The following is a description of a gene set: studied in species Homo sapiens Human Gene Set: GOBP_NUCLEIC_ACID_CATABOLIC_PROCESS The cellular DNA metabolic process resulting in the breakdown of a nucleic acid., and this is the list of marker genes: INTS1, NORAD, FXR2, HSPA1A, PKP3, EXOSC4, MIR142, GTPBP1, ZC3H18 (NCBI Gene Id 124245), MIR181A2, UPF3A, TENT4B, RNPS1, EXOG, CECR2, CNOT9, MIR497, PCBP4, SLIRP, XIST, XRN1, POP1, MIR663A, FASTK, MIR20B, RNASE2 (NCBI Gene Id 6036), MIR608, PNRC1, MIR34B, DNASE1L3, PHAX, RIDA, SETMAR, MIR302A, DNA2, MIR149, PATL1, TRDMT1, DIS3L, MIR708, GATA5, MIR100, FASTKD5, NBAS, NUDT12, SMG6, TBRG4, TENT5D, DIS3, FASTKD1, MIR181D, PNRC2, METTL16, EXOSC9, PLEKHN1 (NCBI Gene Id 84069), LARP1, INTS11, DHX34, RNASEL, AGO4, HOTTIP, BAX, ERI1, CNOT3, ZFP36L1, MIR140, SKIC2, MIR18A, METTL1, PPP1R8, HNRNPD, C1QBP, RBM24, FEN1, PABPC1, XRN2, EIF4A3, NUDT16, ZC3H12A, NOCT (nocturnin), DCP1A, MIR340, INTS3, CAPRIN1, ATM, DFFA, DAZ2, CNOT8, FMR1, ZC3H4, EIF3E, TNRC6B, CNOT10, QKI, MIR214, MIR93, FXR1, AGO3, TARDBP, ELOC, VIM (NCBI Gene Id 7431), MIR130A, OAS2, NBDY, SND1, MIRLET7B, GRSF1, CIDEA, NANOS3, LSM4, TENT5B, GSPT2, CNOT11, NMNAT1, NPM1, DFFB, MIR23A, FASTKD2, MIR181C, MIR27B, INTS10, MIR486-1, DNASE1L2, MIR1-1, APOBEC1, TRAF2, TENT4A, PUM2 (pumilio RNA binding family member 2), ELOB, RBM38, MIR200B, FOXL2, MIR365A, MIR146A, RNASE6, MIR203A, MTPAP, SMG5, A1CF, RBM33, PRR5L, NANOS1, MUS81, TAF15, DEDD2, ELAC2, MIR130B, CIRBP, RNH1, NRDE2 (NRDE-2, necessary for RNA interference, domain containing), INTS15, MOV10, ZPR1, NSUN4, GIGYF2, AKT1, FTO, TNFRSF1B, CELF1, CNOT2, EXOSC1, E2F1, SMG8, SKIC8, HNRNPA0, DCP1B, DNASE1, CALCR, INTS6, ANGEL2, PKP1, WDR82, PABPN1L, YTHDF3, MAGOH, TUT4, CNOT6, RBM8A, PABPC4, ROCK1, EXOSC5, MAPK14, YBX3, IGF2BP3, DIS3L2, MIR625, MIR204, MIR326, TTC5, ROCK2, ZC3H12D, RNASEH2A, THRAP3 (NCBI Gene Id 9967), PELO, CSDE1, SLFN14, FUS, PAN2, HNRNPC, ZC3H14, IREB2, INTS4, TENT2, RNASE3, PNLDC1, DAZ4, UPF1, TESK1, DXO, SLC11A1, MIR200C, MIR199B, ZFP36, CNOT7, KHSRP, MIR329-1, DNASE1L1 (deoxyribonuclease 1 like 1), MIR106A, LSM2, PIWIL1, MIR137, DNASE2B, TREX1, MRTO4, UPF3B, ZCCHC8, MIR128-1, VIP, RC3H2, INTS14, ALKBH5, ELAVL4, NEAT1, PIWIL2 (piwi like RNA-mediated gene silencing 2), MIR302C, SUPV3L1, TNRC6A, CNOT6L, CARHSP1, LARP4B, ARID5A, LSM14B, DAZ3, DDX49, SKIC3, MEIOC, MIR27A, METTL14, NICOL1, TUT7, RBX1, LIN28A, SLFN12, MIR135B (microRNA 135b), DND1, ZHX2, LRPPRC, SERBP1, MIR195, SCGB1A1, IGF2BP2, DHX36, SSB, INTS12, HNRNPAB, DAZL, SAMD4A, POLR2G, OIP5-AS1, MIR30B, DDX5, MIR211, SENP1, ZAR1, ZFP36L2, APAF1, INTS13, PNPT1, MIR125B1, ANG, TUT1, HNRNPU, TOB1, MAPKAPK2, DCPS, DHX9, EIF4ENIF1, ISG20, RNASEH2C, CPEB3, EDC3, CTIF, ERN1, MIR19B1, MIR519A1, PPP2CA, MIR423 (NCBI Gene Id 494335), MIR133A1, FBLL1, MIR106B, AGO1, PYM1, GSPT1, MIR29B1, MIR190B, MTREX, NCBP2, EXOSC10 (NCBI Gene Id 8619), MIR517C, MIR151A (microRNA 151a), TIRAP, PAIP1, DKC1, PUM1, MIR320A, PPP2R1A, NCBP1, TRAF3IP2, RBM7 (NCBI Gene Id 51120), TENT5C, INTS8, FAM76B, CNOT4, GDNF, REXO4 (NCBI Gene Id 90950), FBH1, EXOSC3 (exosome component 3), MIR544A, DICER1, SMG9, MIR424, MIR655, MIR103B1, IGF2BP1, GTSF1, IL6, TNKS1BP1, EXOSC8, MIR24-1, YTHDF1 (YTH N6-methyladenosine RNA binding protein F1), TENT5A, INTS2, PRKCD, MLH1, FASTKD3, RC3H1, LSM1, MIR98, DBR1, MIR210, NUDT16L1, MIR337, MIR373, NSUN2, NT5C3B, LARP1B, EXOSC6, CSDC2, MIR20A, MIR519D, NANOS2, MIR185, HSF1, SYNCRIP, ELAVL1, TRAF5, MIR192, MIRLET7C, LSM6, BOLL, MIR181B1 (microRNA 181b-1), SMG1, LSM5, INTS9, VPS54, YBX1, DCP2, METTL3, ZCCHC7, MIR483, PARN, PRKCA, MIR145, MIR193A (microRNA 193a), MIR520C, MIR212 (microRNA 212), RBM47, ERN2, MIR564, MIR885, MIR9-1, TRIM71, EDC4, MEX3D, MIR125A, HSPA1B, MIR26B, RBM46, RNASEH1, MIRLET7E, RNASET2, IKBKE, YTHDF2, LIN28B, DAZ1, ARMC5, TREX2, DNASE2, MIR19A, MIR543, INTS5, RNASEH2B, SMG7, EXOSC7, MIR96, DNM3OS, NAF1, RBM10, SRSF1, AXIN2, APEX1, MIRLET7A1, MIR206, CASC3, SAMD4B, ZC3HAV1, UPF2, SLFN13, BTG2, SIDT2, CNOT1, ETF1 (eukaryotic translation termination factor 1), TNRC6C, MIR665, MIR485, MIR342 (NCBI Gene Id 442909), MIR495, GTPBP2, MIR191, ZCCHC17, PATL2, MYD88, ENDOG, TRIR, MIR517A, MIR562, TRNT1, SECISBP2, PDE12, LSM7, MIR223, AGO2, MAGOHB, EXOSC2, PIAS4, MIR501, MALAT1, MIR491, MIR4286, CACNG7, ZSWIM8, INTS7, PAN3, HBS1L